Given this list of marker genes KRT19, ACTB, RPS9, JUND, LRRC17, RPS16, SOD1, IFI6, TRIM22, TIMP1, RPL13A, RPS21, RPS5, here is a description of the gene set: Human Gene Set: WHITESIDE_CISPLATIN_RESISTANCE_DN from publication Whiteside MA, Chen DT, Desmond RA, Abdulkadir SA, Johanning GL (PMID 14737109) In recent years, most cDNA microarray studies of chemotherapeutic drug resistance have not considered the temporal pattern of gene expression. The objective of this study was to examine systematically changes in gene expression of NCI-H226 and NCI-H2170 lung cancer cells treated weekly with IC10 doses of cisplatin. NCI-H226 lung cancer cells were treated weekly with an IC10 dose of cisplatin. Candidate genes with a fold change of 2.0 or more were identified from this study. A second experiment was conducted by exposing NCI-H2170 cells to cisplatin doses that were increased in week 4 and decreased in week 5. Overall, genes were differentially expressed in both the NCI-H226 and NCI-H2170 cell lines. In the NCI-H2170 cell line, genes had a twofold gene expression change from weeks 3 to 4. Real-time PCR found a significant correlation of the gene expression changes for seven genes of interest. This small time-ordered series identified novel genes associated with cisplatin resistance. This kind of analysis should be viewed as a first step towards building gene-regulatory networks. Genes down-regulated in NCI-H2170 cells (lung cancer) upon induction of resistance to cisplatin. species: Homo sapiens